Given this list of marker genes TACC2, STMN3, GFRA3, NEGR1, DLL3, RPRM, NCALD, ANKH, NXPH4, RINL, KCNH2, FLT4, KSR2 (NCBI Gene Id 341537), ADAM28, CCDC28B, SNCA, KIF19, TMEM176A, BAALC, KCNA4, RGS4, ELAPOR1, PSD, MIAT (myocardial infarction associated transcript), PPP1R1A, BEX1, RETREG1, NPTX1 (NCBI Gene Id 4884), SST, RASD1, SCG3, KCNH3, RGS7, TCEAL2, DDC, QPCT, SAXO5, TMEM184A, ROBO1, LRATD1, SCN3A, NPW (NCBI Gene Id 283869), MEG3, SEZ6L2, LINC01315, TCEAL7, CFAP65, RET, SMIM32 (NCBI Gene Id 389332), LINC00261, RASA4B, ATP2A3, OTULINL, SCNN1A, NEURL1, MAPK8IP1, MGAT4C, OPTN, GRIK2, CACNA1H, PKIB, CALCA, SRRM4, DUSP26, PGAM2, CHGB, DNAJC12, GNB5, DACH2, FREM1, SLCO3A1, KRT7, EFHD2 (EF-hand domain family member D2), TPBG, SCGN, SCG5, ENO2, SRGAP1, DACH1, LYSMD2 (NCBI Gene Id 256586), MTMR7, HES6, SLC18A1, CAMK2B, CHGA, ST18, CLIP3, USP41P, TMEM51, CACNA1A, CA8, PCSK2, PLPPR2, FGF14, VWA5B2, KLK12, MMP11, PNPLA7, INA, ADA, SLC1A5, KCNJ6, NKAIN2 (NCBI Gene Id 154215), SPHKAP, CXXC4, PRUNE2, NPDC1, TOX3, SLC36A4, AP3B2, JAKMIP2, PROX1, TTC39A, TUBB3, GDAP1, TMEM176B (NCBI Gene Id 28959), RAB3B, CELF3, CAMK1D, CPLX2 (NCBI Gene Id 84242), NOL4, SLC16A11, MARK1, NDUFA4L2, TRMT9B, CBFA2T3, SNAP25, ELAVL4, TAGLN3, SCG2, ESPN, SYT1, BIK, KIF1A, CRMP1, APLP1, RAPGEF4, MAP6, ADGRG1, NRXN1, SIX1, RUNX1T1, NEBL, DEUP1, DPYSL3, COL22A1, DRAIC, ANK2, PDGFD, INSM1, SYT11, AMIGO2, SCAMP5, ARFGEF3, PHGR1, A4GALT, TIMP1, CACNB2, KCNH6 (NCBI Gene Id 81033), SYT5, RHBDL1, HEPACAM2, FAM13C, PDZRN3, LYPD1, SLC35D3, KCNMA1, TMEM178A, GPM6A, ESPL1, TMOD2, DLL4, RGS17, ADCY1, CADM2, SYT4, ADCY2, MS4A8, BEX5, SYT13, MAP1B, REEP2, CHN2, MAOB, ASCL1 (achaete-scute family bHLH transcription factor 1), CHRD, GABRB3, GALNT13, DPP10, TRIM46, RIMKLA, PTPRN2, GCH1 (NCBI Gene Id 93984), NAAA, HOXB5, SLITRK6, DCX, NRSN1, SMIM22, BMERB1 (NCBI Gene Id 89927), GNG4, SMOC2, PKD2L1, CASZ1, CORO7, STX1A, GRIA2, CADPS, BCL2, JAM3, RALYL, DNER, KCND3, PCDH9 (protocadherin 9), IZUMO4, RGS11, RIC3, TENT5A, NR0B2, SMPD3, FSTL5, INHBB, SYP (synaptophysin), RIMS2, GRP, NLRP1, SYBU, CACNA2D1, DTNA, MAPRE3, LHFPL6, KLK11, TCERG1L, here is a description of the gene set: Human Gene Set: HE_LIM_SUN_FETAL_LUNG_C1_PULMONARY_NEUROENDOCRINE_CELL species: Homo sapiens from publication He P, Lim K, Sun D, Pett JP, Jeng Q, Polanski K, Dong Z, Bolt L, Richardson L, Mamanova L, Dabrowska M, Wilbrey-Clark A, Madissoon E, Tuong ZK, Dann E, Suo C, Goh I, Yoshida M, Nikolić MZ, Janes SM, He X, Barker RA, Teichmann SA, Marioni JC, Meyer KB, Rawlins EL (PMID 36493756) Pulmonary neuroendocrine